Given this list of marker genes TMEM38B, RNF34, LGALS9B, FMC1, MAPK6 (NCBI Gene Id 5597), SPCS1, ABCA2, SIGMAR1, HS6ST1 (heparan sulfate 6-O-sulfotransferase 1), ANAPC7, PLA2G15, CNGB3, MEIS3, MT3, IREB2, FKBP7, DPPA2, PTGES, HES5, QRSL1, SPEN, FRMD8, DCPS, CD300C, STAT2, NAA40, SEPTIN7, ANXA6, TNFRSF1A, SLC40A1, BCL2L1, ALG5, EXOC7, ZNF235, VRK2, ENTPD1, CACNA1B, EPC1, HDAC6, FAM98A, NPLOC4, C14orf119, GABRD, PEX19, PRDM5, ZDHHC20, DHX8 (DEAH-box helicase 8), MSL1, RAP1A (RAP1A, member of RAS oncogene family), NFE2L2, CAMK1, RBP3, MSH3, CSTB, CHCHD1, ANKMY2, SERTAD1, WNT2B, CRTAP, YWHAH, UBN1, NDUFS2 (NADH:ubiquinone oxidoreductase core subunit S2), MEPCE, HELLS, NKAIN1, SEL1L, AKAP8 (NCBI Gene Id 10270), HEYL, ZWILCH, SLC7A1, STIP1, CYP4F3, UBE2E3, OCEL1, PIP5K1C, PRKAG1, GPR34, SPC25, IGF2BP3, BLCAP (NCBI Gene Id 10904), MRPL48, SH3BGR, UBXN8, WASF3, RABGGTA, SASH3, BSG, ACVR2B, UBA1, ITGB1BP2, RBX1, PSME3IP1, FUOM, HSPBP1, TSNAX, PRXL2A, SOCS6, SERTAD3, SMPDL3A, RPLP1, ENC1, AKR7A2, NAMPT, NOP10, ZYG11B (NCBI Gene Id 79699), FCGR1A, SRR, CARHSP1, APRT, TRIM32, GLB1L, ACD, CPT1A (NCBI Gene Id 1374), SLC39A11, LGALS1, ST6GALNAC6, RNF2, NOP9, NEU2, WDR81, TFPI, UNC119, SQOR, ADNP, AAGAB, MFSD1 (NCBI Gene Id 64747), PPIF, GRP, CRMP1, NPDC1, CEBPG, C5AR1, TG, CUL4B, SDHC, LMBRD1, NET1, HMGN5, SOCS1, NOG, CCNB2, LGALS8, SRFBP1, MAGEA11, HEATR5B, ATP5PF, ATP6V0D1, IL7 (interleukin 7), HIP1R, DUSP2, TXNDC5, UMOD, EIF3B, DIO1, C5orf47, PGPEP1, SLC37A2, RAB5B, PTPRJ, NCOA2, SLAMF8, ACTL6A, PNPLA8, CIDEB (cell death inducing DFFA like effector b), CEP104, BBLN, MDH2, CHURC1, BRD3, INTS11, ATAD1, HOXB3, EVI5, CREBZF, HNRNPDL, SWSAP1, NELFA, STX19, SLF2, NCLN, TMEM192, TLE5, MRPL11, CLCF1, PSMB2, DNM2, ATG3, TAF13, LARGE1, KRT34 (keratin 34), METTL6, WEE1, ASGR2 (NCBI Gene Id 433), WDR20, ZNF436, LUC7L3, CYP1B1, SNX15, ZNF574, E2F8 (E2F transcription factor 8), here is a description of the gene set: Genes up-regulated in comparison of control dendritic cells (DC) at 1 h versus those stimulated with poly(I:C) (TLR3 agonist) at 1 h. Human Gene Set: GSE17721_CTRL_VS_POLYIC_1H_BMDC_UP from publication Amit I, Garber M, Chevrier N, Leite AP, Donner Y, Eisenhaure T, Guttman M, Grenier JK, Li W, Zuk O, Schubert LA, Birditt B, Shay T, Goren A, Zhang X, Smith Z, Deering R, McDonald RC, Cabili M, Bernstein BE, Rinn JL, Meissner A, Root DE, Hacohen N, Regev A (PMID 19729616) studied in species Homo sapiens mouse primary BMDCs were stimulated with tlr ligands and gene expression changes were profiled on Affymetrix arrays